The following is a description of a gene set: electronically inferred by orthology from the curated human pathway studied in species Mus musculus This event has been computationally inferred from an event that has been demonstrated in another species.<p>The inference is based on the homology mapping from PANTHER. Briefly, reactions for which all involved PhysicalEntities (in input, output and catalyst) have a mapped orthologue/paralogue (for complexes at least 75% of components must have a mapping) are inferred to the other species. part of: MITF-M-dependent gene expression Reactome Pathway: Regulation of MITF-M-dependent genes involved in apoptosis, and this is the list of marker genes: Mitf, Sin3a, Hint1